Given this list of marker genes Socs7, Grin1, Idh2, Dcx, Nr2e1, Cers2, Dab2ip, Apcdd1, Cd9, Mmp14 (NCBI Gene Id 17387), Fn1, Efemp1, Lamb1, Tspo, Cspg4, Zmiz1, Sun2, Wdr47, Ccl2, Hexb, Matn2, Ntn1, Fubp1, Syne2, P2ry1, Cdk5r1, Cx3cl1, Pi4ka, Scrib, Col3a1, Gli3, Ccr2, Sun1, Cdk5, Tiam1, Foxg1, Ptprz1, Enpp1, Pmp22, Ulk4, Epha4, Disc1, Srgap2, P2rx4, Rras, Ndn, Vcan, Stap1, Pafah1b1, Trem2, Bmerb1, Ptprb, Tgfb2, Cx3cr1, Dab1, Mboat7, Nf1, Ccl3, Arhgef7, Ccl12, Adgrg1, Cdk5r2, Crkl, Atp1b2 (NCBI Gene Id 11932), Rras2, Gpr183, Reln, Vim, Fas, P2ry12, Rtn4, Lrp8, Lrp1, Csf1 (colony stimulating factor 1 (macrophage)), Ctnnb1, here is a description of the gene set: studied in species Mus musculus Mouse Gene Set: GOBP_GLIAL_CELL_MIGRATION The orderly movement of a glial cell, non-neuronal cells that provide support and nutrition, maintain homeostasis, form myelin, and participate in signal transmission in the nervous system.